The following is a description of a gene set: studied in species Homo sapiens The progression of the venous blood vessel over time from its initial formation to the mature structure. Venous blood vessels carry blood back to the heart after the capillary bed. Human Gene Set: GOBP_VENOUS_BLOOD_VESSEL_DEVELOPMENT, and this is the list of marker genes: NOTCH1, TBX20, SEMA3C, ACVRL1, NKX2-5, CCM2, FOXF1, EFNB2, VEGFA, CCBE1, HEG1, PITX2, APLNR, PROX1 (prospero homeobox 1), ENG, BMPR2, ACVR2B